The following is a description of a gene set: species: Homo sapiens We demonstrate that the G protein Gi3 is the cellular target of the adenosine A3 receptor (A3R). By using a cell permeable peptide comprising the C-terminal end of Gαi3 fused to an importation sequence (ALL1) as a selective inhibitor of Gi3 signaling, we show that by coupling to Gi3, the A3R stimulates multiple signaling pathways in human mast cells, leading to upregulation of cytokines, chemokines and growth factors.Following contact with activated T cell membranes, endogenous adenosine binds to and activates the A3R, resulting in Gi3-mediated signaling. Specifically, the majority of ERK1/2 signaling initiated by contact with activated T cell membranes, is mediated by Gi3, giving rise to ALL1-inhibitable cellular responses. These results unveil the physiological GPCR that couples to Gi3 and establish the important role played by this G-protein in inflammatory conditions that involve adenosine-activated mast cells. We used microarrays to detail the effect of ALL1 on gene expression of HMC-1 cells activated directly by the A3 receptor, or by contact with activated T cell membranes. from publication Baram D, Dekel O, Mekori YA, Sagi-Eisenberg R (PMID 20190146) Human Gene Set: GSE19888_ADENOSINE_A3R_INH_VS_INH_PRETREAT_AND_ACT_WITH_TCELL_MEMBRANES_MAST_CELL_DN Genes down-regulated in HMC-1 (mast leukemia) cells incubated with the peptide ALL1 versus those then stimulated by T cell membranes., and this is the list of marker genes: ELAVL4, TSPAN8, PHKG1, CCDC122, NXPE4, RHBG, CST8, CFI, USP9Y, PXDC1, NWD2, KHDC3L, LEF1, EHD3, HLA-B, PCYOX1L, CRB3, S100A14, KLF17, WDR64, ARRDC2, ZP2, SERPINB11, ADAT2, CFAP300, LRRC3B, IVNS1ABP, FGF12, PROZ, VNN2, ZFP92 (ZFP92 zinc finger protein), DNAJC16, KDELR2, AANAT, KCNC3, PRDM16, SOWAHB, OLFM4, GAREM2, ATP1B3, C4orf17, RAB9B, TYR, ICOS, ACOT11, NEU2, PRR32, MORN4, XPNPEP2, DSC2, TINAG, SLC25A48, NXPE2, SYCP1, PAX1, IL20, TAGLN3, POLR1B (RNA polymerase I subunit B, NCBI Gene Id 88998), GALNT13, EPHB1, FAM107A, PAM, CDHR5, SPDEF, KLK7, EPCAM, PTPRN2, PLAAT3, MMP20, VTN, BICD1, SLC30A10, TMPRSS3, PPP1R36, SPINK8, KCNK10, MICALL1, CRCT1, NPTXR, MBOAT4, DPPA5, HNF4G, GNRHR, CD9, CHRNA6, ZNF276, BORCS5, EXOSC1, TGIF2LX, DACH1, RHBDF2, SUN2, NEUROG3, MIER2, SAMD11, SLC5A9, AJUBA, TMEM71, SYT4, SCNN1A, FN3KRP, CASKIN1, H2AB2, SLC19A1, SLC15A2, IGKC, GUCA2B, DUSP5, VN1R5, COL4A6, SLC5A11, SCNN1B, KCNS2, GALNT2, CSTF1, PRPH, SLC22A2, IL5, CBLN2, CACNG5, IL12A, MYO1D, TERT, TRANK1, DFFA, UBE2QL1, OTP, SDC1, NXPH2, TMEM163, GABRA1, CHCHD4, TMPRSS15, TRIO, SPEN-AS1, ELOVL5, DZANK1, FNDC7, MANSC1, SPATA3, CAPN6, GABRP, RPS3A, TMEM217, LHFPL5, TMEM52B, RPL27A, POLR2F, SGIP1, TUBB4B, SLC22A12, BEST1, SP8, STK40, PNPLA3, TMEM177, OR11H4, BLK, ADAMDEC1, SOAT2, PKHD1L1, ATP1B1, GDPD3, TREML1, DCLRE1B, ETS2, SH3TC2, NETO1, SUSD4, HSD17B14, CPB2, PAN3, LYPLAL1, ERICH3, TRPM5, CISH, HMGXB3, ARGLU1, IQGAP1, KCNIP1, PROB1, KCNMB4, PCDH10, TOMM34, HAO2, TMEM269, MS4A18 (NCBI Gene Id 728588), ZFP14, NEUROD4, CNFN, F7, SNRPD3, PLXNA3, ARHGAP39, SLC34A3, ICAM5, ZNF385C